Given this list of marker genes Fech, Star, Map1b, Scn3a, Cyp1a1, Inhbb, Th, Nr4a2 (NCBI Gene Id 18227), Scn1b, Scn2b, here is a description of the gene set: Any process that results in a change in state or activity of a cell or an organism (in terms of movement, secretion, enzyme production, gene expression, etc.) as a result of an insecticide stimulus. Insecticides are chemicals used to kill insects. Mouse Gene Set: GOBP_RESPONSE_TO_INSECTICIDE species: Mus musculus